Given this list of marker genes Anxa7, Nfe2l1, Cers2, Urah, Htatip2, Cbx7, Acox1, Krt18, Tpx2, Ccdc80, Nabp2, Iqgap2, Hip1, Cdkn1a, Trim24, Atp11c, Entpd5, Rint1, Bub1, Txnip, Nr1h4, Sirt2, Fah, Fdxr, Bhlha15, Trim62, Nf2 (neurofibromin 2), Myc, Ranbp2, Plau, Fbxo4, Prkar1a (NCBI Gene Id 80472), Lzts1, Ccndbp1, Ikbkg, Prdx1, Bub1b, Mzf1, Becn1, Stk11, Sav1, Bhmt, Ndrg2, Psmb9, Mc4r, Rassf5, Mcm4, Eaf2, Abcb4, Sod1, Ccnd1, Rassf1, Fhit, Gfer, Pten, Sptbn1, Trp53, Mad1l1, Smurf2, Atm, Lgals3, S100a4, Stag1, Foxm1, Ncoa5, Uaca (uveal autoantigen with coiled-coil domains and ankyrin repeats), Apc, Map3k7, Gnmt, Mcm9, Mir122, Hic1, Tnk1, here is a description of the gene set: from publication Motenko H, Neuhauser SB, O'Keefe M, Richardson JE (PMID 26092688) studied in species Mus musculus Mouse Gene Set: MP_INCREASED_HEPATOCELLULAR_CARCINOMA_INCIDENCE Mouse genes annotated to increased hepatocellular carcinoma incidence (MP:0003331) retrieved from the Mouse Genome Informatics database via MouseMine